Given this list of marker genes BCL2L1, HTR2A, CASP8, DFFA, DLC1, MIRLET7B, GCG, CASP10, FAP, BOK, PTGIS, NDUFA13, HTRA2, CXCR3, FZD3, RIPK1, TNFRSF1A (TNF receptor superfamily member 1A), TP53BP2, MIR15A, ZC3H12A, TP53, SIRT2, HSPD1, CIDEA, MIR30B, FADD, CASP9, here is a description of the gene set: Any process that modulates the frequency, rate or extent of execution phase of apoptosis. Human Gene Set: GOBP_REGULATION_OF_EXECUTION_PHASE_OF_APOPTOSIS studied in species Homo sapiens